Given this list of marker genes MPPED1, TFDP2, GPM6A, RELB, ST6GAL1 (ST6 beta-galactoside alpha-2,6-sialyltransferase 1), DYNC2LI1, TTN, ANXA2P1, SMCHD1, MCL1, AEBP1, STS (NCBI Gene Id 6802), MC5R, GRN, DZIP3, SETBP1, CD55, ADAM19, FOLR1, PEX2 (peroxisomal biogenesis factor 2), PLG, RGS2 (NCBI Gene Id 5997), CTF1, TNFAIP1, RAPGEF5, PTPN21, MSH3, NT5E, TADA3, PDGFRA, FCHSD2, HEXA, IRF4, MAST3, DPY19L2P2, GARRE1, CLCN4, STAT6, ZBTB18, SNAPC2, HDAC9, TMT1A, MIA2, PLAGL1, RIMS3, CRYM, ADARB1, MTSS1, PRKCB, LRP10, RNGTT, PHEX, RHOBTB1, RALGPS1, TRIB2, DTX4, PDIA5, IL4R, VPS13B, XYLT1, TMX4, SERPINF1, UVRAG, YIPF1, TNFAIP8, EVI5, SPINT2, FST, SERPINB8, MAPK12, MTMR6, EXOC3, IRS1, PPP1R16B, TRAT1, DNMBP, SIT1, SLC17A4, SBSPON, HRK, DNASE1L3, KPNA6, BTK, PTAFR, EPHX2, NADK, GNAZ, DAAM1, GPR18, HERPUD1, SETX, NIPA2 (NCBI Gene Id 96367), OAS2, CD22, CBLB, ADAM23, CD19, CD180, RPS6KA2, PIM2, ROR1, CD72, MKRN3, ESYT1, PLCL2, PTPN2, CTDP1, POM121L9P, SLC25A4 (solute carrier family 25 member 4), HABP4, RIPOR2, ZFP36, TNFRSF17, CXCL2 (NCBI Gene Id 2920), WASF1, SMAD7, FIG4, STX7, MTMR1, MYO1C, EMP3, SIPA1L3, PTPN18, ACSM3, H2BC21, ATP2B1, RGS4, SPIB, PSD4, RYK, ZSCAN9, BNIP2 (NCBI Gene Id 663), ABCB4, RHOH, PDLIM1 (NCBI Gene Id 9124), APLP2, VDR, LAMA5, PPP1R26, SPG11, DENND4A, SH2B3, KMO, LYN, GORASP1, GSDME, CARD10, IQCE, TBC1D1, CCDC69, DOP1B, GATAD1 (GATA zinc finger domain containing 1), BCL7A (BAF chromatin remodeling complex subunit BCL7A), TJP1, VNN2, H3C4, TES, PIP5K1B, ZKSCAN4, PSEN2 (presenilin 2), TRIM22, IBTK, LYST, CEMIP, CYLD, SIK1, SP110, RNF41, TACC1, APBB2, AGL, SH2B2, AOX1, SP100, CD38, GUCY2C, CYTH1, IRAG2, CAND2, MGLL, HCK, CXCL3, SGCE, POU4F1, GAS7, RNF13, IFNGR2, BTG1, RGS16, MTCL1, TGFBR2, PHF8, ZEB2, BLCAP, RASGRP1, S1PR1, RNASE6 (ribonuclease A family member 6), SUSD6, here is a description of the gene set: from publication Baranek T, Manh TP, Alexandre Y, Maqbool MA, Cabeza JZ, Tomasello E, Crozat K, Bessou G, Zucchini N, Robbins SH, Vivier E, Kalinke U, Ferrier P, Dalod M (PMID 23084923) Human Gene Set: GSE39556_CD8A_DC_VS_NK_CELL_DN Genes down-regulated in CD8A dendritic cells versus NK cells. studied in species Homo sapiens The injection of the pathogen-associated molecular pattern Polyinosinic-polycytidylic acid (poly(I:C)) leads to the activation of various immune cells, including dendritic cells (DCs) and Natural Killer (NK) cells. This activation is due to different innate cytokines produced early after injection, in particular IFN-I. The objective of the study was to compare the pattern of expression of IFN-I stimulated genes between DC and NK cells. The project focused on a specific subset of conventional DC, CD8a DC, which responsiveness to IFN-I determines the capacity to activate CD8 T cells by cross-presentation of exogenous antigens. To identify the responses to IFN-I selectively induced in CD8a+ DC, we compared their gene expression profile to that of NK cells, using gene chips, before and after poly(I:C) stimulation.